The following is a description of a gene set: part of: DNA strand elongation This event has been computationally inferred from an event that has been demonstrated in another species.<p>The inference is based on the homology mapping from PANTHER. Briefly, reactions for which all involved PhysicalEntities (in input, output and catalyst) have a mapped orthologue/paralogue (for complexes at least 75% of components must have a mapping) are inferred to the other species. studied in species Mus musculus Reactome Pathway: Unwinding of DNA electronically inferred by orthology from the curated human pathway, and this is the list of marker genes: Gins3 (NCBI Gene Id 78833), Gins1